The following is a description of a gene set: Human Gene Set: GOBP_NEGATIVE_REGULATION_OF_MICROTUBULE_DEPOLYMERIZATION species: Homo sapiens Any process that stops, prevents, or reduces the frequency, rate or extent of microtubule depolymerization; prevention of depolymerization of a microtubule can result from binding by 'capping' at the plus end (e.g. by interaction with another cellular protein of structure) or by exposing microtubules to a stabilizing drug such as taxol., and this is the list of marker genes: CLASP1, BMERB1, ARHGEF2 (NCBI Gene Id 9181), GAS2L1, TRIM54, TAOK1, CKAP2, CIB1, BBOF1 (NCBI Gene Id 80127), SPECC1L, TTBK2, HDAC6, WDR47, TPX2, HDGFL3, MAP6D1, STMN2, CAMSAP2, APC, MID1, ATXN7, SPEF1, MID1IP1, DIAPH3, NAV3, KATNB1 (katanin regulatory subunit B1), APC2, GAS2L2 (NCBI Gene Id 246176), CLASP2, CCDC88C, MAP1B, FGF13